Given this list of marker genes EDNRA (NCBI Gene Id 1909), NLN, TAC3, NPFFR1, ACKR3, MT-RNR2, ACKR4, SST, CXCL2, CXCL3, CXCL10, PYY, HCRTR2, GALR3, CCL1, XK (X-linked Kx blood group antigen, Kell and VPS13A binding protein), EDNRB, C3, PPBP, XCL2, CCR9, SSTR1, C5, RLN3, MC3R, ACKR1, OPRD1, CXCR4, CCL11, UTS2B, ANXA1, APP, GPR37, GRPR, CX3CR1, GALR2, QRFP, CCL4, CCL13, CCL27, PF4, NPFF, NMUR1, CCL28, BDKRB2, POMC, NPFFR2, PNOC, CCL23, KISS1R, RXFP3, EDN2, OPRK1, MC1R, XCL1, PPY, MLNR, XCR1, RXFP4, NPBWR2, TRHR, MAS1 (NCBI Gene Id 4142), OXT, PSAP, APLNR, MC4R, GHSR, OXTR (oxytocin receptor), MLN, PRLHR, SSTR3, NMU, NPY5R, NTS, NPBWR1, GPER1, TAC1, CCL16, UTS2R, CCL3, C5AR2 (complement C5a receptor 2), EDN3, QRFPR, AVP, FPR2, KNG1, CXCL16, OPRM1, GALR1, NMS, SSTR2, MRGPRD, SSTR4, AGTR2, CCK, AGT, CXCL11, HEBP1, PDYN, F2, GAL, CX3CL1, C5AR1, CXCR5, PMCH, CCR10, CXCR6, NTSR2, KISS1, CCL19, ECE1, CXCL5, CCKAR, NPY, MC5R, CCR7, F2R, CCR2, CCR3, APLN, CXCR2, CCL22, FPR1, NMB, GPR37L1, CCRL2, CORT, MC2R, CXCL13, PRLH, SSTR5, PROKR2, NPY4R, CXCR1, NPY1R, CCR6, CXCL9, MCHR1, NPB, CCR8, ECE2, TACR3, CXCR3, CCL7, BRS3, AVPR1A, AVPR2, CCR5 (C-C motif chemokine receptor 5), AGTR1, BDKRB1, GRP, OPRL1, CXCL6, EDN1, AVPR1B, CCL21, HCRTR1, CCL5, CCL25, INSL5, GHRL, RXFP2, TACR2, CCL3L1, F2RL2, SAA1, CCL20, CCR1, C3AR1, CXCL8, TRH, CCL2, INSL3, NTSR1, NPY2R, F2RL3, NPW, PROK1, FPR3, PROK2, F2RL1, HCRT, MCHR2, KEL, TACR1, NPS (NCBI Gene Id 594857), NPSR1, UTS2, ACKR2, PROKR1, CCKBR, RLN2, PENK, CCL17, CXCL12, RXFP1, NMUR2, NMBR, CXCL1, CCR4, here is a description of the gene set: studied in species Homo sapiens These receptors, a subset of the Class A/1 (Rhodopsin-like) family, all bind peptide ligands which include the chemokines, opioids and somatostatins. Reactome Pathway: Peptide ligand-binding receptors part of: Class A/1 (Rhodopsin-like receptors)